Given this list of marker genes Ptch1, Gas1, Hhip, Shh, Ihh, Dhh, Cdon, here is a description of the gene set: Mouse Gene Set: REACTOME_LIGAND_RECEPTOR_INTERACTIONS Ligand-receptor interactions studied in species Mus musculus